The following is a description of a gene set: studied in species Homo sapiens Human Gene Set: REACTOME_GENE_AND_PROTEIN_EXPRESSION_BY_JAK_STAT_SIGNALING_AFTER_INTERLEUKIN_12_STIMULATION Gene and protein expression by JAK-STAT signaling after Interleukin-12 stimulation, and this is the list of marker genes: AIP, SOD1 (superoxide dismutase 1), IFNG, CNN2, STAT4, LCP1, RPLP0, HNRNPA2B1, MIF (NCBI Gene Id 4282), TALDO1, HNRNPDL, ANXA2, HNRNPF, PSME2, MTAP, PAK2, IL10, SERPINB2, LMNB1, RAP1B, HSPA9, CDC42, PITPNA, PDCD4, BOLA2B, MSN, GSTO1, CAPZA1, CFL1, SNRPA1, SOD2, ARF1, RALA (RAS like proto-oncogene A), TCP1, CA1, PPIA, GSTA2, BOLA2